The following is a description of a gene set: Werner syndrome (WS) is a premature aging disorder, displaying defects in DNA replication, recombination, repair, and transcription. It has been hypothesized that several WS phenotypes are secondary consequences of aberrant gene expression and that a transcription defect may be crucial to the development of the syndrome. We used cDNA microarrays to characterize the expression of genes and ESTs across a panel of 15 primary human fibroblast cell lines derived from young donors, old donors, and WS patients. Of the analyzed genes, 6.3% displayed significant differences in expression when either WS or old donor cells were compared with young donor cells. This result demonstrates that the WS transcription defect is specific to certain genes. Transcription alterations in WS were strikingly similar to those in normal aging: 91% of annotated genes displayed similar expression changes in WS and in normal aging, 3% were unique to WS, and 6% were unique to normal aging. We propose that a defect in the transcription of the genes as identified in this study could produce many of the complex clinical features of WS. The remarkable similarity between WS and normal aging suggests that WS causes the acceleration of a normal aging mechanism. This finding supports the use of WS as an aging model and implies that the transcription alterations common to WS and normal aging represent general events in the aging process. Human Gene Set: KYNG_NORMAL_AGING_UP from publication Kyng KJ, May A, Kølvraa S, Bohr VA (PMID 14527998) Genes distinctly up-regulated in primary fibroblast cultures from normal old donors compared to those from normal young donors. species: Homo sapiens, and this is the list of marker genes: RTCB, EIF3L, SOAT1 (sterol O-acyltransferase 1), SHC3, TAF10, PMEPA1 (NCBI Gene Id 56937), FRA10AC1, ZNF260, SAT1, SNX8, GNAL, ITGA2, CDIN1, PLD3 (phospholipase D family member 3), GOLPH3